Given this list of marker genes Nrg3, Erbb4, Btc, here is a description of the gene set: species: Mus musculus Reactome Pathway: PI3K events in ERBB4 signaling This event has been computationally inferred from an event that has been demonstrated in another species.<p>The inference is based on the homology mapping from PANTHER. Briefly, reactions for which all involved PhysicalEntities (in input, output and catalyst) have a mapped orthologue/paralogue (for complexes at least 75% of components must have a mapping) are inferred to the other species. part of: Signaling by ERBB4 electronically inferred by orthology from the curated human pathway